The following is a description of a gene set: species: Mus musculus Mouse Gene Set: GOCC_SITE_OF_DNA_DAMAGE A region of a chromosome at which DNA damage has occurred. DNA damage signaling and repair proteins accumulate at the lesion to respond to the damage and repair the DNA to form a continuous DNA helix., and this is the list of marker genes: Ddb2, Paxx, Rnf138rt1, Prpf19, Smarcad1, Smc6 (structural maintenance of chromosomes 6), Uimc1, Rpa1, Htatsf1 (NCBI Gene Id 76595), Macroh2a1 (macroH2A.1 histone), Rnf168, Aplf, Kdm4d, Wdr70 (NCBI Gene Id 73770), Xpc, Smarca5, Rad51, Asf1a, Sirt6, Ddb1, Was, Eloa, Rnf138, Wdr76, Polq, Slfn9, Hus1, Ints3, Trp53, Cgas, Inip, Parp3, Atf2, Shld3, Rpa2, Sirt7, Arpc4, Topbp1, Xrcc4 (NCBI Gene Id 71945), H2ax, Vcp, Ufl1, Cbx3, Rad18, Zbtb7a (NCBI Gene Id 71606), Dynll1, Pnkp, Nkx3-1, Shld1, Cbx5, Stk38, Mdc1, Adprs, Mad2l2, Exd2, Cbx1, Arpc3, Polk, Smc5, Arpc1a, Spindoc, Hpf1, Rad50, Xrcc5 (NCBI Gene Id 98297), Rbbp8, Rhno1, Helq, Arpc5, Chd4, Hus1b, Rnf8, Atm (NCBI Gene Id 77416), Aunip, Traip, Actr3, Rfwd3, Slfn8, Smarcal1 (SWI/SNF related matrix associated, actin dependent regulator of chromatin, subfamily a-like 1), Rad17, Hrob, Setmar, Cyren, Ubqln4, Smchd1, Mms22l, Atr (ataxia telangiectasia and Rad3 related), Helb, Samhd1, Mbtd1, Phf1, Shld2, Xrcc1 (X-ray repair complementing defective repair in Chinese hamster cells 1), Slf2, Chd1l, Iffo1, Rnf169, Aim2, Ercc6, Actr2, Nhej1, Cntd1, Arpc2, Nabp1, Wrap53, Timeless, Dmc1, Parp9 (NCBI Gene Id 80285), Mre11a, Peli1, Poll, Esco2, Rif1, Parp1, Zmynd8, Nabp2, Lmna, Kat5, Cul5, Oard1, Brme1 (break repair meiotic recombinase recruitment factor 1), Trp53bp1, Nbn, Epc1, Kat7, Rpa3, Tonsl, Parp2, Fh1, Polh, Slf1